Given this list of marker genes PTPN20, PTPN23, STAT3, IL18R1, PTPN14, TBK1, PTPN5, PTPN4, SIGIRR, CASP1, PTPN11, PTPN6, IL18BP, PTPN18, SMAD3, PTPN9, PTPN13, PTPN2, PTPN7, PTPN12, IL37, here is a description of the gene set: Human Gene Set: REACTOME_INTERLEUKIN_37_SIGNALING studied in species Homo sapiens Interleukin-37 signaling